Given this list of marker genes Sema3g, Tbxa2r, Repin1, Me1, Phf3, Kctd1, Vbp1, Qser1, Setd3, Jam3, Pirb, Plekhb2, Ttc7, Spty2d1, Tmod3, Ltn1 (NCBI Gene Id 98040), Kpna3, Cenpi, Erbb4, Cbx5, Ndst1, Abcc5, Col7a1, Itch, Il36rn, Tex12, Tulp4 (NCBI Gene Id 78646), here is a description of the gene set: from publication Chen Y, Wang X (PMID 31504780) Mouse Gene Set: MIR_1251_5P studied in species Mus musculus Genes predicted to be targets of miRBase v22 microRNA mmu_miR_1251_5p in miRDB v6.0 with MirTarget v4 prediction scores > 80 (high confidence targets).